Given this list of marker genes PSMB1, KARS1, SNRPD3, ZNF207, PES1, SLC7A5P1, SNRPC, TRA2B, PTBP1, PABPN1, RPL26L1, SAP18, KHDRBS1, TRMT112, RBM4, MRPL9, ILF2, PSMD4, EIF4A1, EPRS1, PSMB7, U2AF1, PSMA6, WBP11, CPSF6, SUMO2, NUP62, DHX15 (DEAH-box helicase 15), RTRAF, UBE2I, EIF3B, XRCC6, EXOSC8 (exosome component 8), UTP18, PSMG2, SRSF3, here is a description of the gene set: Neighborhood of G22P1 Human Gene Set: GNF2_G22P1 Neighborhood of G22P1 NULL in the GNF2 expression compendium studied in species Homo sapiens